The following is a description of a gene set: species: Mus musculus Mouse Gene Set: GOBP_PROTEIN_LIPID_COMPLEX_ORGANIZATION Any process in which macromolecules aggregate, disaggregate, or are modified, resulting in the formation, disassembly, or alteration of a protein-lipid complex., and this is the list of marker genes: Bin1, Ces1g, Lipc, Mttp, Pla2g7, Apoa1, Pla2g10, Plagl2, Apoc1, Snx9, Ces1d, Mfsd2a, Arf1, Acsl3, Soat2, Gpihbp1, Apoc3, Scarb1, Nr1h4, Pla2g5, Lpl, Pnliprp2, Apob, Pla2g12b, Nr1h2, Abcg1, Pltp, Dgat1, Apom (NCBI Gene Id 80543), Apoe, Sh3gl2, Pla2g3, Cideb, Soat1, Abca1, Abca5, Apoa2, Lipg, Pcdhga3, Pla2g2e, Lcat, Apoa5, Pnlip, Abca7, Pnliprp1, Fech, Mpo, Lpcat3, Apoa4